Given this list of marker genes Dcps (NCBI Gene Id 69305), Pabpc1, Elavl1, Cnot2, Cnot6l, Plekhn1, Mir144, Gtpbp1, Ago2, Tob1, Rc3h1, Prr5l, Mir196a-1, Parn, Tent4b, Rc3h2, Gigyf2, Piwil2, Syncrip, Gtsf1, Piwil1, Zc3h12a, Nanos1, Pum1, Tardbp, Dnd1 (NCBI Gene Id 21746), Tent4a, Qki, Fxr2, Ttc5, Nanos2, Hnrnpr, Zfp36l1, Btg2, Mir7578, Mir196a-2, Cpeb3, Dhx36, Zc3hav1, Samd4b, Tnrc6b, Piwil4, Zc3h12d, Dcp2, Caprin1, Paip1, Noct, Pde12, Celf1, Rock1, Pabpn1l, Zfp36 (NCBI Gene Id 22695), Tut4, Dcp1b, Patl2, Cnot6, Tnrc6c, Ago3, Rock2, Zfp36l3, Ythdf2, Rida, Khsrp, Pan2, Fxr1, Tut7, Upf1 (UPF1 RNA helicase and ATPase), Cnot7, Ythdf3, Mex3d, Mov10, Nanos3, Pan3, Trim71, Tnrc6a, Samd4, Mlh1, Lsm1, Hnrnpu, Dhx9, Cnot8, Mettl16, Dcp1a, Hnrnpd, Csde1, Mir451a, Pnldc1, Mettl14, Ybx1, Alkbh5, Rbm24, Eif4enif1, Mettl3, Pnpt1, Ythdf1, Cnot1, Mir451b, Mir196b, Igf2bp1, Cnot3, Fto, Polr2g, Patl1, Zfp36l2, Dis3l2, here is a description of the gene set: studied in species Mus musculus Any process that increases the rate, frequency, or extent of a mRNA catabolic process, the chemical reactions and pathways resulting in the breakdown of RNA, ribonucleic acid, one of the two main type of nucleic acid, consisting of a long, unbranched macromolecule formed from ribonucleotides joined in 3',5'-phosphodiester linkage. Mouse Gene Set: GOBP_POSITIVE_REGULATION_OF_MRNA_CATABOLIC_PROCESS